Given this list of marker genes ADAM18, ECEL1, TIMP2, ADAMTS1, ADAM23, YME1L1, RARRES1, THOP1, MMP27, COL4A3, ADAMTS20, MMP17, KEL (NCBI Gene Id 3792), ATP23, NLN, TLL1, ADAM32, ADAM28, ZMPSTE24, TIMP3, ADAM33, ADAM9, ADAMTS19, TIMP4, RECK, SPG7, NGF, RCE1, ECE2, ADAMTS3, ADAMDEC1, ADAM19, PITRM1, TRABD2A, PRSS2, PAPPA, ADAMTS4, ADAMTS10, MMP15, MMP2, MMP28 (matrix metallopeptidase 28), PMPCB, ACE, PMPCA, MMP8, IDE, NRDC, MMP24, MMP26, BST2, MMP23B, FETUB, SPRTN, ADAM29, YBEY, CLCA2, MME, ADAMTS9, ADAM30, ADAMTS18, ADAM20, SPOCK3, ECE1, ADAM15, PAPPA2 (NCBI Gene Id 60676), ADAMTS5, ADAMTS8, BMP1, MMP3, MMP21, KLK7, MMP25, TIMP1 (TIMP metallopeptidase inhibitor 1), ADAM22, ADAM17, LXN, ADAMTS14, CLCA4, CIROP, ADAM12 (NCBI Gene Id 8038), ASTL, MIPEP, EEF1AKMT4-ECE2 (NCBI Gene Id 110599583), TRABD2B, LMLN, SPOCK1, ADAMTS7, MMP19, MMP7, CLCA1, ADAM10, ADAM11, MBTPS2, ADAMTS6, MMP12, ADAM8 (NCBI Gene Id 101), MMP9, ADAMTS16, ADAMTS13, UQCRC2, ADAMTSL2, TMPRSS6, MMP13, ADAM7, MEP1A, ADAM2, MMP1, ADAMTS15, MMEL1, MMP16, SPOCK2, OMA1, AFG3L2, MMP14, ADAM21, MEP1B, ADAMTS12, ADAMTS17, MMP10, MMP20, PHEX, TLL2, ADAMTS2, MMP11, here is a description of the gene set: Human Gene Set: GOMF_METALLOENDOPEPTIDASE_ACTIVITY studied in species Homo sapiens Catalysis of the hydrolysis of internal, alpha-peptide bonds in a polypeptide chain by a mechanism in which water acts as a nucleophile, one or two metal ions hold the water molecule in place, and charged amino acid side chains are ligands for the metal ions.